Given this list of marker genes SLC7A7, OTC, COX16, CA5A, GLS, ASL, NAGS, LIPT1, ASS1, here is a description of the gene set: An increased concentration of glutamine in the blood. Human Gene Set: HP_HYPERGLUTAMINEMIA Hyperglutaminemia studied in species Homo sapiens